The following is a description of a gene set: Binding to a U1 small nuclear ribonucleoprotein particle. Human Gene Set: GOMF_U1_SNRNP_BINDING studied in species Homo sapiens, and this is the list of marker genes: LEMD3, SNRNP70, SNRPD1 (small nuclear ribonucleoprotein D1 polypeptide), SNRPB (NCBI Gene Id 6628), RBM39, SNRPA, RBM23